The following is a description of a gene set: studied in species Homo sapiens Human Gene Set: GOBP_KERATINIZATION The process in which the cytoplasm of the outermost cells of the vertebrate epidermis is replaced by keratin. Keratinization occurs in the stratum corneum, feathers, hair, claws, nails, hooves, and horns., and this is the list of marker genes: LCE3B, CASP14, KRT71, CERS3, KRT83, KRTAP6-1, LCE1A, CDSN, KRT4, KRT74, KRT6C, KRT16, KRT80, LIPK, TMEM79, KRT7, KRT75, CNFN, LCE5A, SFN, KRT5, KLK5, LCE7A, KRT2, SPRR1B, SPRR2D, KRTAP6-3, KRT17, PPHLN1, LCE2B (late cornified envelope 2B), ABCA12, LCE6A, KRT72, LIPM, IVL, TCHH, LCE3D, KRT76, LCE3E, KRT1, KAZN, TGM1, KRT78, LCE3C, LCE2A, KRTAP6-2, KRT85, LCE1F, TGM3, PPL, KRT6B, CYP26B1, LCE1B, LCE1E (late cornified envelope 1E), SPRR4, LCE1D, KRT77, LCE4A, SHARPIN, SPRR1A, LCE2D, EVPL, KRT84, KRT73, SPRR2F, KRT3, SPRR3, LCE1C, SPRR2G, KRT79, KRT82, LIPN, LORICRIN, KRT86, HRNR, KRT6A, SPRR2B, LCE3A, KRT81 (NCBI Gene Id 3887), SPRR2E, CDH3, LCE2C